Given this list of marker genes Ihh, Nppc, Prdx5 (NCBI Gene Id 54683), Mrc2, Cst3, Rcn3, Rapgef3, F2, Serpinf2 (NCBI Gene Id 18816), Col1a2, Il6ra, Tram2, Tgfb1, Id1, Mmp19, Creb3l1, Mmp17, Mmp21, Retreg3, Adora2b, Mmp27, Pdgfrb (NCBI Gene Id 18596), Emilin1, Mmp25, Vps33b, Vim, Adam15, Adamts2, Vipas39, Fap, Prss2, Itga2, Col5a1, Suco, Mmp3, Scx, Col6a1, Ager, Nr1h4, F2r, Tns2, Ucn, Fn1, Prtn3, Mmp9, Mmp16, Fosl2, Ltbp1, Ctsl, Inhba, Mmp1a, Mmp11, Hif1a, Tmem131, Fgfr3, Mmp7, Prkcd (protein kinase C, delta), Bmp4, Idua, P3h4, P3h2, Tgfb3, Ccl2, P2rx7, Smpd3, Ctss, Mmp23, Got1, Adamts3, Cbx8, Mmp14, P3h3, Eng, Retreg1, Rgcc, Larp6, Itgb1, Mmp1b, Ppard, Mmp28, Myb, Serpinh1, Acvr1b, BC004004, Cyp2j6, Serpinb7, Il18, Tnxb, Vsir, Serpine1, Ctsk (cathepsin K), Retreg2, Il6, Ddr2, Errfi1, P3h1, Mkx, Uts2, Retn, Mmp13, Mmp10, Pparg (peroxisome proliferator activated receptor gamma), Naglu, Ep300, Pdgfb, Dicer1, Arrb2, Rap1a (RAS-related protein 1a), Mmp24, Plod3, Ccn2, Pepd, Tgfbr3, Mmp2, Ctsb, Mmp12, Gli2, Notch1, Arg1, Mmp15, Cyp7a1, Mmp20, Mfap4, Wnt4, Cygb, Col1a1, Mmp8, here is a description of the gene set: Mouse Gene Set: GOBP_COLLAGEN_METABOLIC_PROCESS The chemical reactions and pathways involving collagen, any of a group of fibrous proteins of very high tensile strength that form the main component of connective tissue in animals. Collagen is highly enriched in glycine (some regions are 33% glycine) and proline, occurring predominantly as 3-hydroxyproline (about 20%). species: Mus musculus